Given this list of marker genes Hand2os1, Foxh1, Smarcd3, Nkx2-5, Tbx20, Sox4, Notch1, Sema3c, Hand2, Isl1, Gata3, Gata4, Chd7, Hey2, Zfpm2, Bmp4, Bmpr1a, Ppp1r13l, Jag1, Hand1, Tgfb2, here is a description of the gene set: Mouse Gene Set: GOBP_CARDIAC_RIGHT_VENTRICLE_MORPHOGENESIS The process in which the right cardiac ventricle is generated and organized. studied in species Mus musculus